Given this list of marker genes Entpd8, Pnp2, Tymp, Pnp, Nudt1, Nt5c1b, Entpd3, Entpd2 (ectonucleoside triphosphate diphosphohydrolase 2), Entpd7, Nudt16, Upb1, Nt5c, Nudt9, Entpd5, Nudt5, Nt5c2, Gda, Adprm, Nt5c1a, Nudt18, Dpyd, Nudt15, Xdh, Upp1, here is a description of the gene set: studied in species Mus musculus Reactome Pathway: Nucleotide catabolism part of: Metabolism of nucleotides This event has been computationally inferred from an event that has been demonstrated in another species.<p>The inference is based on the homology mapping from PANTHER. Briefly, reactions for which all involved PhysicalEntities (in input, output and catalyst) have a mapped orthologue/paralogue (for complexes at least 75% of components must have a mapping) are inferred to the other species. electronically inferred by orthology from the curated human pathway